Given this list of marker genes Taf1, Mpc1, Ube2q2, Rtn1, Caprin2, Rnf150, Tle4, Npas3, Ccnj, Bcl11b, Arid4a, Arid4b, Cdkn1a (NCBI Gene Id 12575), Gpc6, Col17a1, Kif26b, Fndc3a, Crim1, Pak2, Phc3, Glod4, Prdm8, Armc8, App, Rgmb, Rbl2, Rb1cc1, Marchf8, Mospd2, Sf3b1 (splicing factor 3b, subunit 1), Cd200, Mylk, Smc2, Zfp800, E2f5, Flt1, Nhsl3, Nsd3, Zfp362, Rassf2, Rab22a, Tnfaip1, Mllt6, Kmt2a, Coro2b, Clock, Kremen1, Dgkq, Sar1b, Map3k14, Cdk6, Sdc1, Tmem72, Tet1, Crot, Fgd5, Med12l, Rab5c, 2410002F23Rik, Krt222, Pak5, Golga1, Ppp1r3e, Syde1, Nufip2, Ptpn21 (NCBI Gene Id 24000), Slc22a23, Zfyve26, Kdm1b, Tgfbr2, Ncoa7, Dcp1b, Micu1, Kpna2, Nfib (NCBI Gene Id 77183), Zfp9, Asf1b, Gpr158, Ect2, Zbtb41, C87436, Lhx6, Bcl6, Cyp26b1, Jazf1, Dcdc2a, Arhgef17, Irf2, Osmr, Sowahc, Ythdf3, Smarcc2, Lrit1, Myocd, Adam9, Tmub2, Fam168b, Hif1an, Parp8, Lgr4, Fzd3, Epha2, Erc1, Vmn1r45, Shc4, Rab11a, Pcdh7, Cxadr, Suco, Vldlr, Ddias, Hipk3, E2f2, Usp24, Zfp148, Znrf3, F3, Slc6a9, Lefty2, Unkl, Rbl1, Spop, Tmem123, Cdca7, Hlf, Mier3, Ezh1, Ash1l, Atxn1, Mettl21c, Elavl2, Olig2, Rab8b, Arnt2, Ss18l1, Rest, Hs2st1, Zbtb43, Glis3, Mtf1 (metal response element binding transcription factor 1), Elk4, Cpeb1, Dpp8 (NCBI Gene Id 76430), Nr2c2, Ambn, Ube2b, Tmem35b, Synpo2, Mycn, Trpv6, Myrf, Prdm16, Kcnb1, Dcun1d4, Prdm4, Irf9 (interferon regulatory factor 9), Slc30a10, Tmtc1, Lrat, Tnrc18, Uap1, Fgd4, Fgf9, Clptm1l, Srcin1, Asap1, Arhgap29 (Rho GTPase activating protein 29), Macc1, Rps6ka1, Atf6b, Nr2c1 (nuclear receptor subfamily 2, group C, member 1), Zfp53, Wdr48, R3hdm1, Malt1, Snx8, Aak1, Ankrd17, Slc7a2, Asf1a, Irf2bp2, Pou6f1, Prrg1, Nfia, Kcnd2, Pip4k2a, Lhx8, Lats2, Rnf216, Rictor, Hmbox1, Akr1c21, Trim36, Zcchc24, Btg1, Asxl3, Zkscan1, Tapt1, Cnot6l, Cnot6, Reep3, Yod1, Dcaf6, Txnip, Tiparp, Marchf11, Ddhd1, Ago1, Unk, Mtmr3, Ism2, Slc5a10, Erap1, Pde3b, Map3k2, E2f7, Twf1, Slc49a4, Ccnd1, Nfya, Cfl2, Tfap4 (transcription factor AP4), Arhgef10, Pbx3, Kmt5b, Ednrb, Ak2, Trip11, Tiam1, Miga2, Epha5, Rock2, Ryr2, Plagl2 (pleiomorphic adenoma gene-like 2), Ssr1, Gm5622, Ppp1r36, Cluh, Ikzf2, Bloc1s5, Mtus1, Zbtb11, Zfp367, Ptprb, Myo5a, Mink1, Skida1, Retreg3, Suv39h1, Kat2b, Rsbn1, Lefty1, Slf1, Itgb8, Rnf6, Zfp827, Zbtb5, Unc80, Wdr1, Tox, here is a description of the gene set: Genes predicted to be targets of miRBase v22 microRNA mmu_miR_302d_3p in miRDB v6.0 with MirTarget v4 prediction scores > 80 (high confidence targets). studied in species Mus musculus from publication Chen Y, Wang X (PMID 31504780) Mouse Gene Set: MIR_302D_3P